The following is a description of a gene set: Human Gene Set: MORF_CTSB Neighborhood of CTSB cathepsin B in the MORF expression compendium Neighborhood of CTSB species: Homo sapiens, and this is the list of marker genes: LPAR4, MYT1, LECT2, KPNA1, DGCR5, RBBP7, CA3, ATXN3, PSD, PHOX2B (paired like homeobox 2B), PPM1E, HOXB7, ZNF157, SLC14A2, EDIL3, SMYD3, ARFGEF2 (ADP ribosylation factor guanine nucleotide exchange factor 2), ADAMTSL3, RB1CC1, ATF2, EXOC4, CTSB, IL7, IFNA2, ADAM20, COL8A1, SUPT3H, CCN6, JADE3, MAGEA9, FOSL1, ZSCAN26, MAGEA8, PDE6H, CBLN1, GPR171, HOXC11, HNF1A, B4GALT6, ITGBL1, RAD51D, COL19A1, MDM2 (NCBI Gene Id 84825), MC5R, GPR19, SLC17A3, ATP4B, IFNW1, PCDHB17P, CADM4, F2RL1, CPB2, SPRR2C, FZD5, CYP2E1, PCM1, OR2B6, GRIK1, PAX6, CRHR1, IFNA1, ANXA10, ZNF202, DRD1, TACC2, RXRG, KLRC4, CDC73, LILRA1, STAC, PTPRR, OTC, MAP2K7, SOCS6, CMKLR2, GNG4, PLPPR4, CDKL5, PVR, REPS2, TTTY1, PRKCA, MAP2, CALN1, SIX6, PTPN20, MYH2, DNAJC22, GPD2, ZNF132, KRT2, SERPINA4, BRINP3, USP46, SLC46A3, NR3C2, SLC6A2, LGI1, MPP3, TENM4, HCRTR2, LILRA4, NR1I2, APOBEC1, UBE4B, ATF6B, TBXT, CAMK4, RYR3, GCM1, SLC17A1, ATP2B2, NTNG2, TSHB, SEMA6A, AMMECR1, PSG1, PDE6A, FGA, SPA17, CAMTA1, JRKL, RORB, HSD3B2, CCR3, LRP6, IPO9, CDR1, GHRHR, GLRA3, CEP162, ABCB1 (ATP binding cassette subfamily B member 1), PRPS1L1, MINDY2, GPR18, SLC15A1, LRP4, IFNA14, TBX19, NEB, AKAP3, RNF24 (ring finger protein 24), DAZL, IFNA10, P2RY10, DMPK, TRIO, SOX11, ZBTB14, MPZL1, GJB5, CHRNB4, PLXNA3, TNK1, RREB1, RSC1A1, GABRB2, ST8SIA1, SULT4A1, POLR1HASP, GPR15, BRD4, PHF10, NPFF, MLLT10 (NCBI Gene Id 8028), ZBTB40 (NCBI Gene Id 9923), PART1, NHEJ1, HTR1E, KCNA5, CDH8, CLCN3, EDN3, SRPK3 (NCBI Gene Id 26576), NPAS2, TANC2, SLC4A4, DMD, TLL1, ADRB1, KRT34, FSHR, IL4, ATP8A2, TNIK, OR7A5, LDB3